The following is a description of a gene set: studied in species Homo sapiens from publication Szanto A, Balint BL, Nagy ZS, Barta E, Dezso B, Pap A, Szeles L, Poliska S, Oros M, Evans RM, Barak Y, Schwabe J, Nagy L (PMID 21093321) Genes down-regulated in macrophages (12h): control versus rosiglitazone and IL4. Human Gene Set: GSE16385_UNTREATED_VS_12H_ROSIGLITAZONE_IL4_TREATED_MACROPHAGE_DN Human CD14 positive monocytes were purified from healthy volunteers’ blood and cultured in vitro for 4, 12, 24, 72 hours. While culturing, macrophages were activated alternatively with interleukin-4 (IL-4 100 ng/ml) or classically with interferon-gamma (IFNg 100 ng/ml)+tumor necrosis factor (TNF 50 ng/ml) or left without activation. Simultaneously, macrophages were also treated with vehicle (DMSO:ethanol) or 1mM synthetic PPARg agonist, Rosiglitazone. We used Affymetrix microarrays (U133Plus 2.0) to analyze activation and PPARg-induced gene expression changes., and this is the list of marker genes: COG7 (NCBI Gene Id 91949), GEMIN6, WNT1, P2RX2, PSMA5 (proteasome 20S subunit alpha 5), MRPS33 (NCBI Gene Id 65515), TXNDC9 (NCBI Gene Id 10190), EIF3E, NANOG, PEAR1, RYR3, HPRT1, SEPTIN3, AP1S2, CRISPLD2, SNW1 (SNW domain containing 1), RAPH1, PLAC9, BARX2, ACP1, EBAG9, ADCY1, SEC61B, IFT88, PTGR3, LORICRIN, RPF2, NEK7, SRP14, FANCL, VGLL1, HNRNPA0, RPP30, GPR85, HBA2, NME2, EIF3H, ASZ1 (ankyrin repeat, SAM and basic leucine zipper domain containing 1), CWF19L2, SCAPER, AAK1, LNX1, RAB3GAP1, GRM4 (glutamate metabotropic receptor 4), UPK3BL1, PRKACB, TENT5B, PIGH, WDR11, CIPC, TULP4, METTL18, CHRAC1, SRMS, CNIH4, GPR135, QDPR, NDUFA12, CES5A, ATP8A2, AOC1, CIBAR1, TMOD2, GNG10, CFAP97, EFCAB12, TAF4B, SUCO, BCLAF3 (BCLAF1 and THRAP3 family member 3), ARNT2, HOXB3, UGT3A2, TMX1, NAB1, ADAMTS9, TM9SF2, UPK2, LONRF2, POLR2J, FGFR2, PPP1CC, SHISAL1, FGF10, INSIG2, NDUFB3, CHD6, MSI1, CEP19, AGTPBP1, NEFL, SOX18, APPL1, IGLON5, SLC35E4 (NCBI Gene Id 339665), SFRP4, RGMB, DOCK4, FAM76B, MICALL2, TLR5, RBX1, SREK1IP1, TTC1, TMC5, FHAD1, PDE7B, ALOX5AP, MTDH, COMMD8, ALDH1A2, CUTC, ELP4, GNAQ, MYL4, SNHG11, SWT1, FHIT, SLIRP, SDSL, AKAP9, GMNN, FOXI1, CRP (NCBI Gene Id 1401), FRRS1L, SV2A, STAG2 (STAG2 cohesin complex component), KY, OR51E1, URI1, C6, SLC4A7, UFSP1, VKORC1L1, ATG5, SPRR3 (small proline rich protein 3), ANKRD13C, FRY, RASSF10, LEP, RGS4, FBXO8, NEIL3, FBXO41, VDAC3, NOS1, THEM4, OSTC, RAP2C, MED13, MKKS, DUS1L, PIGA, TMEM128, CR1L, ZNF334, MTRES1, LMOD3, MYCBP2, TNFAIP8, NMD3, PREX2, UNC5C, POLR3K, BDNF, XPR1, SAMTOR, RIOK1, STEAP3, POLDIP3, DNMT3B, PSMD14, ALG5, NIPBL, KLHL32, LRR1, ZNF638, PDP2, OTC, STARD6, MCCC1, RTRAF, GATA6, TRIP4, STARD7, SLC26A8, ERICH3, ZNF8, MRPS18C, BCAM, PPP1R13L, IMMP1L, PSMA2, TM4SF4, NRG2, PXDC1, FANCB, SELENOF, DCTPP1, WDR3, MFAP3L